The following is a description of a gene set: Genes having at least one occurence of the motif GTGTCAA in their 3' untranslated region. The motif represents putative target (that is, seed match) of human mature miRNA hsa-miR-514 (v7.1 miRBase). Human Gene Set: GTGTCAA_MIR514 studied in species Homo sapiens, and this is the list of marker genes: PTEN, AGAP1, RAB3A (RAB3A, member RAS oncogene family), CPNE8, FOXO4, TCF12, C2CD5, OAZ2, PRICKLE2, ZNF536, PIK3C2B, ARRDC3, TAL1, AFF4, PPM1F, SYT11, NRXN3, FAM117A, DHX57, ARHGEF9, RBX1, BRWD1, TSPAN9, ZNF282, TAOK2, VAT1, AR, ZIC1, FZD4, NAV3, GRM8, NR3C1, USO1, KMT2A, PPIL1, MYO1B, UBQLN2, PPP3R1, SCN3A, IGBP1, ARFGAP2, PPP2R1A, ST8SIA2, C7, ENAH, EXOC5, CCNE2, SVIL, ERC2, KLF13, EIF4ENIF1, CARM1, ANAPC1P2, RNF19B, PTPRG, TRIM2, NCOA7, BAALC, COL2A1, ZBTB41, PCCA